Given this list of marker genes Fcsk, Nlgn3 (NCBI Gene Id 245537), Ajap1, Septin5, Esrrb, Palm, Iqgap2, here is a description of the gene set: studied in species Mus musculus Mouse Gene Set: MIR_6409 from publication Chen Y, Wang X (PMID 31504780) Genes predicted to be targets of miRBase v22 microRNA mmu_miR_6409 in miRDB v6.0 with MirTarget v4 prediction scores > 80 (high confidence targets).